Given this list of marker genes H2-M3 (NCBI Gene Id 14991), Tmem100, Gadd45gip1, Akr1a1, Cotl1, Lrrc25 (NCBI Gene Id 211228), Nfic, Ccdc80, Fcer1g, Pld4, Cox4i1, Rpl6, Syngr2, Swi5, Aga, Aamp, Eef1d, Map1lc3a, Clic1, Rpl32 (NCBI Gene Id 19951), Selenos, Lum, Naca, Gpsm3, Fbln1, Atp5mc2, Tspan7, Tyrobp, Krt15, Basp1, Klk8, Rps6, Cfl1, Pou2f2, Rps7, Rpl5, Snhg20, Tmed9, Pfn1, Rpl10, Usp2, Tagln2, Tle5 (NCBI Gene Id 14797), Ly6e, Clu, Bst2, Rps9, C1qb, Chst1, Tmsb10, Erp29 (endoplasmic reticulum protein 29), Gpr84, Cdkn1a, Psmb9, Dad1, Arpc1b, Xist, Sf3b2, Prr13, Ap2s1, Rbm3, Cst3, Aldoa, Tspo, Itm2c, Adrm1, Cd37, Atp5f1d, Serping1, Vim, Rabac1, Eef1a1, Rps14, Gpx4, Atp6v0e, Rps10, Cd48, Prdx1, Pi16, Rps3a1, Rpl17, Myl6, Gng10, Trex1, Krt14, Psmb8, Cd68, Oaz1, Shisa5 (NCBI Gene Id 67794), Cd52, Rpl12, Lsp1, Gstm1, Capg, Rps24, Tmsb4x, Trem2, Rps18, Apoe, Syf2, Tmed3, Snrpc, Rpl18, Mgp, Lgals3bp, Ctss, Tmem86a, Ldhb, Lat2, Rps11 (ribosomal protein S11), Rpl4, Fabp4, Ly6a (lymphocyte antigen 6 family member A), Bri3, Mbp (NCBI Gene Id 98130), Rpl19, Lamtor4 (NCBI Gene Id 66096), Hebp1, Tmem160, Arrb2, Rpl18a, Gpx1, Ptma, Abi3, Clec7a, Rpl14, Nme2 (NCBI Gene Id 18103), Ociad1, Eif3f, Rpl3, Rpl13, Anapc11, Ifitm3, Arhgdib, Tpt1, Rps16, Lyl1, Slc43a3, Anxa5, Tspan4, Rnaset2b, Arpc3, Timp2, Rbm26, Irf8, Gnptg, Slc25a3, Psmd4, Ptms, Lamtor1, C1qc, Lpl, Pkm (pyruvate kinase, muscle), Eif3h, Arl8a, Gltp (NCBI Gene Id 97217), Rpl27a, Ppp1r35, Ifi30, Sdhc (succinate dehydrogenase complex, subunit C, integral membrane protein), Rps2, Cd74, Orai1 (ORAI calcium release-activated calcium modulator 1), Rpl11, Ctsl, Tm4sf1, Rrp1, Fcgr2b (Fc receptor, IgG, low affinity IIb), Rps27a, Rps5, Fuca1, Fis1 (fission, mitochondrial 1), Ppp1r11, Chmp2a, Tnfsf13b, Ndufb9, Ssbp4, Gsn, Pfdn5, Lmo2, Rpl7a, Camk1, Gabarap, Rps13, Vps28, Chst8, Rack1, Pomp, Cd9, Coro1a, Rpl29, Vti1b, Rtp4, Sdf4, Lag3, Tex261, Dpysl2, Selenow, Rpl24 (ribosomal protein L24), Crlf2, Tomm6, Rpl7, Tsc22d4, Thrsp, Gnb1, Pkig, Bgn, Arpc4, Ybx1, Cd63, Rplp2, Arhgdia, Cdc37, Eif5a, H2-Eb1, Ppp1r18, Cd300c2, Tmem50a, Capzb, Slc25a5, Serbp1, Calm2, Fth1, Pold4, Emc10, Rpl21, Cxcl16, Rps4x, Syngr1, Tpm3 (NCBI Gene Id 59069), Spi1, Grina, Atp6v0b, Arhgap45, Plp1, Ldha, Rpl13a (NCBI Gene Id 80550), Rplp0, Cadm1, Prelid1, H2-D1 (NCBI Gene Id 547343), Naxe, Ubxn1, Slamf9, H2-K1, Rpl10a, Eef1b2, Limd2, Exosc5, Ddah2, Rpl28, Ctsh, Rgs10, Gapdh, Csnk2b, Wbp2, Lyz2, Cyba, Ddhd2, H2-Ab1, Psme1, Reep5 (receptor accessory protein 5), Prdx5, Eif3k, Crybb1, C1qa, Zfp710, Cd81, Pabpn1, Drap1, H2-DMa, Scn1b, Ube2m, Ddrgk1, Rpl35, Atp6v0c, Bsg, Ftl1, Upk1b, Ifi27, Srgn, Rpl9, Cox7a2l, Stx16, B2m (NCBI Gene Id 12010), Mid1ip1, Kdelr1, Rpl8, Dcn, Naa80, Cxcl1, Ypel3, Gpx3, Plekho1, Rpl23, Sf3b4 (NCBI Gene Id 223612), Itm2b, Emc7, Pebp1, Tubb6, Ywhae, Srsf9, Npm1, Efhd2, Plekhj1, Ctsz, Trim35, Laptm4a, Gcg, Rps3, Slc25a4, Lgals9, Dok1, H2-Aa, Sparc, Csf2ra, Aif1, Vkorc1, Sh3bgrl3, Ctsb, Ubb, Igfbp4, Ino80e, Rps20, Rplp1, Npc2, Hhex, Anxa2, Calm1, Rpsa, here is a description of the gene set: Mouse Gene Set: TABULA_MURIS_SENIS_BRAIN_MYELOID_MICROGLIAL_CELL_AGEING studied in species Mus musculus from publication Tabula Muris Consortium (PMID 32669714)